The following is a description of a gene set: from publication Ross ME, Mahfouz R, Onciu M, Liu HC, Zhou X, Song G, Shurtleff SA, Pounds S, Cheng C, Ma J, Ribeiro RC, Rubnitz JE, Girtman K, Williams WK, Raimondi SC, Liang DC, Shih LY, Pui CH, Downing JR (PMID 15226186) studied in species Homo sapiens Contemporary treatment of pediatric acute myeloid leukemia (AML) requires the assignment of patients to specific risk groups. To explore whether expression profiling of leukemic blasts could accurately distinguish between the known risk groups of AML, we analyzed 130 pediatric and 20 adult AML diagnostic bone marrow or peripheral blood samples using the Affymetrix U133A microarray. Class discriminating genes were identified for each of the major prognostic subtypes of pediatric AML, including t(15;17), t(8;21), inv(16), MLL chimeric fusion genes, and cases classified as FAB-M7. When subsets of these genes were used in supervised learning algorithms, an overall classification accuracy of more than 93% was achieved. Moreover, we were able to use the expression signatures generated from the pediatric samples to accurately classify adult de novo AMLs with the same genetic lesions. The class discriminating genes also provided novel insights into the molecular pathobiology of these leukemias. Finally, using a combined pediatric data set of 130 AMLs and 137 acute lymphoblastic leukemias, we identified an expression signature for cases with MLL chimeric fusion genes irrespective of lineage. Surprisingly, AMLs containing partial tandem duplications of MLL failed to cluster with MLL chimeric fusion gene cases, suggesting a significant difference in their underlying mechanism of transformation. Human Gene Set: ROSS_LEUKEMIA_WITH_MLL_FUSIONS Top 100 probe sets associated with MLL fusions irrespective of the lineage of the pediatric acute leukemia., and this is the list of marker genes: DACH1, MICAL1, JMJD1C, CLASP2, PCDHGC3, SIDT2, HOXA9, ANXA5, SCP2, HTR1F, DAD1, CCL5, ARPC2, LIPC, KLRK1, ALDH3A2, ADCY9, IGFBP7, ZEB2, ENDOG, GPM6B, CSPG4, SENP6, MYO6, DAB2, BMI1, MRPL33, ZNF274, PROM1, ADAM10, HOXA4 (NCBI Gene Id 3201), GLT8D1, CORO1C, HOXA10, CES1, PBX3, LPCAT1, HCLS1, PARP8, LAMP5, PSMD7, HOXA7 (homeobox A7), ABCA7, C11orf24, ZSCAN18, VLDLR (very low density lipoprotein receptor), PLD3, FAIM (Fas apoptotic inhibitory molecule), SCPEP1, MYO5C, RBKS, ITGA7, MBNL1, PNMA8A, LILRA1, AKR7A2, RNASE3, ARL6IP5, FEZ1, AK2, HIF1A, ENSG00000274253, POP5 (POP5 homolog, ribonuclease P/MRP subunit), TIGAR, HEXB, RHOBTB3, MEIS1, RAC2, NKG7, DEXI, CAPG, MAP3K5, HOXA5, MYH9, PALLD, CCND2, CCL23, PTPRC, LGALS1